The following is a description of a gene set: species: Homo sapiens CD8+ T cells play a crucial role in the clearance of intracellular pathogens through the generation of cytotoxic effector cells that eliminate infected cells and long-lived memory cells that provide enhanced protection against reinfection. We have previously shown that the inhibitor of E protein transcription factors, Id2, is necessary for accumulation of effector and memory CD8+ T cells during infection. Here we show that CD8+ T cells lacking Id2 did not generate a robust terminally-differentiated KLRG1hi effector population, but displayed a cell-surface phenotype and cytokine profile consistent with memory precursors, raising the question as to whether loss of Id2 impairs the differentiation and/or survival of effector-memory cells. We found that deletion of Bim rescued Id2-deficient CD8+ cell survival during infection. However, the dramatic reduction in KLRG1hi cells caused by loss of Id2 remained in the absence of Bim, such that Id2/Bim double-deficient cells form an exclusively KLRG1loCD127hi memory precursor population. Thus we describe a role for Id2 in both the survival and differentation of normal CD8+ effector and memory populations. from publication Knell J, Best JA, Lind NA, Yang E, D'Cruz LM, Goldrath AW (PMID 23325888) Human Gene Set: GSE41978_ID2_KO_VS_BIM_KO_KLRG1_LOW_EFFECTOR_CD8_TCELL_UP Genes up-regulated in KLRG1 low CD8 T effector cells during infection: ID2 knockout versus BCL2L11 knockout., and this is the list of marker genes: SAMD9, CALCOCO2, PLSCR1, RABGAP1L, ISG15, PSMB9, ICAM1, HLA-E, NFE2L3, TMEM121, CSTF3, FOSL2, FAS, TXNL4B, CASP7, C5orf15, IFIT3, PLAAT4, NMI, DENND4A, CLPX, SCN9A, MX1, OAS3, SCO2, SNX7, CYB5A, CLEC2B, IRF9, CSF1, TCL6, ADAR, TEAD4 (NCBI Gene Id 7004), ARHGAP29, RTP4, IRF1, ZC3HAV1, PARP12, APOL1, TRIM44, FLT3LG, HLA-B, ZNF410, RPA2, PSMB10, TRIM22, TLR3, PCDHGA11, B2M, LIPT1, IL15, SERPING1, PTPRC, GCNT3, IFIT5, TMEM140, LSM6, SHFL, CEBPB, F2, BATF3 (NCBI Gene Id 55509), MAFF, GBP2, HLA-J, OGFR, DRAM1, GBP1, APOL6, HK1, TRIO, MSRB1, FNBP4, IL1R1, NR4A2, BCL6, IFI6, SOCS1, UBE2L6, C1S, ATP10D, HNRNPH2, IFIT1, SNRPF, TAP2, LDLR, NR1H2, DDX23, CREM, IL12A, ARID5B, SLC12A7, WARS1, RIGI, TRAT1, SOD2 (superoxide dismutase 2), CEP63, DENND5A, IFI35, C3, CTSL, ZFP36, IL32, BST2, KLF4, OASL, RBCK1, CXCL2, PVR, TRIM38, NBN, MYD88, BACH1, C1R, IRF7, GCLM, HLA-G, IDO1, TAP1, ISG20, RBM4, C1orf115, IFI30, TAPBP, IGFLR1, CXCL10, CAND2, CASP8, PEX11A, CD47, SQOR, CFH, CXCL11, MAX, STK3, PSME2, JAK2, SECTM1, KDSR, IRF8, IFIH1, STAT3, PHF11, GSTK1, GTF2B, ITK, CTSS, HDAC4, PSMB8, RNF114, APOL3, CCDC68, RAB27A, HSPB8, LGALS3BP, IL15RA, LAP3, HYAL1, DDX60, HEG1, TRIM14, TRAFD1, LTBR, HLA-C, CXCL5, CCL2, TASOR2, PANX1, RMND1 (NCBI Gene Id 55005), SYNE2, PML, STAT1, RNF19B, IFITM3, PLSCR4, SCN1A, IL10RB, MSX1, BCO1, IFI16, TRIM21, PMAIP1, CEBPD, KIF18A, SP100, USP33, DNAJC12, RARS1, APOL2, HLA-A, VILL, SLC25A28, MET, BTN3A3, VPS9D1, SP110, TOP1, RCN1, SNRK (SNF related kinase), DYRK4